Given this list of marker genes VEGFD, VEGFC, VEGFB, VEGFA, PGF, SWAP70, here is a description of the gene set: studied in species Homo sapiens Human Gene Set: GOBP_POSITIVE_REGULATION_OF_MAST_CELL_CHEMOTAXIS Any process that increases the rate, frequency or extent of mast cell chemotaxis. Mast cell chemotaxis is the movement of a mast cell in response to an external stimulus.